Given this list of marker genes LEP, KLF7, MIDN, VSNL1, CCN3, SIRT4, CRH, INHBB, GNAI1, NDUFAF2, BMP8A, GNAO1, PFKL, MTNR1B, ADRA2A, IRS1, PDE8B, PRKN, NPFF, CRHBP, FFAR4, JAGN1, F2RL1, SYTL4 (NCBI Gene Id 94121), GNAZ, CARTPT, ADRA2C, DRD2, CD74, FKBP1B, GHRL (NCBI Gene Id 51738), ABCC8, FFAR2, FOXO1, CHGA, REST, ENY2, KCNJ11, PSMD9, PIM3, UCP2 (NCBI Gene Id 7351), KCNB1, SREBF1, HADH, PTPN11, ACVR1C, FAM3D, GHSR, here is a description of the gene set: Any process that stops, prevents, or reduces the frequency, rate, or extent of peptide secretion. Human Gene Set: GOBP_NEGATIVE_REGULATION_OF_PEPTIDE_SECRETION studied in species Homo sapiens